The following is a description of a gene set: We identified Pparg as a major orchestrator of the phenotype of adipose-tissue resident regulatory T cells (VAT Tregs). To establish the role of Pparg in shaping the VAT Tregs gene profile and cell dynamics, Tregs from lymph nodes and visceral adipose tissue of mice sufficient and deficient of Pparg expression in Tregs were double sorted for microarray analysis. Human Gene Set: GSE37532_VISCERAL_ADIPOSE_TISSUE_VS_LN_DERIVED_PPARG_KO_TCONV_CD4_TCELL_DN from publication Cipolletta D, Feuerer M, Li A, Kamei N, Lee J, Shoelson SE, Benoist C, Mathis D (PMID 22722857) species: Homo sapiens Genes down-regulated in T conv cells from aged PPARG knockout mice: visceral adipose tissue versus lymph node., and this is the list of marker genes: SERPINB2, OR1D2, TMEM150A, ACOT4, CNNM3, MAMSTR, MC3R, SNORD118, SLC27A2, CADM3, DTNA, SNORA61, S1PR5, USP18, MRM1 (NCBI Gene Id 79922), GSTM2, MIR301B, ZNF394, CES5A, MIR150, SLC5A11, SNORA74A, SIPA1L1, SLC43A1, PLEKHM1, GNB1L, CREB3L2, TDRD1, SLC9A8, GPR17, FETUB, GKN1, SLC25A42, PLA2G1B, SZT2, CFB, DGAT1, CALHM4, TSHZ2, ENSG00000212553, NAV2, CSN1S2AP, SPACA3, TARS2, AMBRA1, HELZ, RXRA, TTC39A, BACH2, MTOR, PEAR1, TGFB2, DENND1C, BNC2, NXPE1, HTR4, TRAPPC9 (trafficking protein particle complex subunit 9), CCDC158, KRTAP6-2, UPP1, CNTN4, CSAD, SLC44A4, SNORA3A, SYNE1, ATF7, TBC1D17, CACNB2, CACHD1, SNORA75, SPOCK1, CNMD, ADCY1, FSIP2, HCRTR1, GPM6A, AS3MT, ACER1, SULT1C2, SLC17A1, ENTPD4, SNHG11, PDE10A, NMS, EYA2, TGM2, PRM1, PLIN2 (NCBI Gene Id 123), CABIN1, NPHS2, NID1, RHBDD2, OPN5, LRRN1, ZPLD1, H1-2, SCML4, GABBR1, GCN1, TAS1R2, ANKK1, ASB17, TMEM63B, CCDC88C